Given this list of marker genes POLK, AICDA, CALML4, XPR1, BRINP1, PCDH20, ADD1, BSN, ZNF624, SLC36A4, ST8SIA6, RIPOR1, GABRB2, VPS54, IPMK, DKK1, ZNF572, PRKAR1B, SCN9A (sodium voltage-gated channel alpha subunit 9), PDGFD, UGCG, UGT8, ZNF189, PROX1, ZNF660, ZNF347, LYPD6, RAB1A, ROBO2, RNF115, NFASC (NCBI Gene Id 23114), NSA2, DLG3, CASK, TACC1, CASD1, ZIC4, AUTS2, CDK16, ZNF268, TENT5A, PAX6, KMT5B, MMP16, ABCA1, SREBF1, ZFYVE28, SETD7, OGFRL1, SLC38A2, MTMR6, KLHDC9, EPHA7, ARL13B, C6orf62, SERTAD2, SETD5, SESN3, RASL11B, PDE4D, BHLHE22, TSHZ2, BOD1L1, PTPRK, SPTLC2, CMTR2, PDS5B, LPCAT2, SLC25A4, PDXDC1, WDR44, SLC1A6, CDYL2, PDPK1, GPALPP1, INO80D, SCARB2 (NCBI Gene Id 950), TMEM47, DPPA5, GREM2, TEX56P, CDH11, TRPC1, SGCE, GRM8, here is a description of the gene set: species: Homo sapiens from publication Chen Y, Wang X (PMID 31504780) Genes predicted to be targets of miRBase v22 microRNA hsa-miR-1912-5p in miRDB v6.0 with MirTarget v4 prediction scores > 80 (high confidence targets). Human Gene Set: MIR1912_5P